The following is a description of a gene set: Low hanging columella species: Homo sapiens Columella extending inferior to the level of the nasal base, when viewed from the side. Human Gene Set: HP_LOW_HANGING_COLUMELLA, and this is the list of marker genes: TAF6, CTNNB1, KNL1, HIVEP2, RYR1, CNTNAP2, EDEM3, GJA8, SOX11, BICRA, MGAT2, ATN1 (NCBI Gene Id 1822), KAT6A (lysine acetyltransferase 6A), KMT2D, SMARCA2, CKAP2L, PUM1, PQBP1, RAC1, UBE2A, KDM3B, H3-3B, POC1A, PCDHGC4, SRCAP, AHDC1, ZFX, CTCF, CLP1, TBCD, KMT5B, EP300, NOG, TWIST1, AFF3, ZMIZ1 (zinc finger MIZ-type containing 1), ASXL3, RNU4-2, CAPN15, SETD2, GJA5, ZEB2 (NCBI Gene Id 9839), CAPRIN1, AIMP2, HNRNPR, HNRNPH2, ZNF148, THOC6, CDH11, TRIO, TRIP12, LIFR, CREBBP, KDM5B, PPP1R21, CDC42BPB, CLCN3, ITCH, CEP295, GJA1